The following is a description of a gene set: Catalysis of the hydrolysis of a peptide bond not more than three residues from the N- or C-terminus of a polypeptide chain by a catalytic mechanism that involves a catalytic triad consisting of a serine nucleophile that is activated by a proton relay involving an acidic residue (e.g. aspartate or glutamate) and a basic residue (usually histidine). Mouse Gene Set: GOMF_SERINE_TYPE_EXOPEPTIDASE_ACTIVITY studied in species Mus musculus, and this is the list of marker genes: Cpvl, Hpn, Dpp7, Prcp, Ace, Prss16, Tpp2, Tpp1, F11, Scpep1, Ctsa